The following is a description of a gene set: Human Gene Set: REACTOME_SYNTHESIS_OF_WYBUTOSINE_AT_G37_OF_TRNA_PHE Synthesis of wybutosine at G37 of tRNA(Phe) species: Homo sapiens, and this is the list of marker genes: TYW1, TRMT12, TRMT5, TYW5, TYW3, LCMT2